The following is a description of a gene set: Pathway Definition from KEGG: LacCer -- >> B4GALT1/2/3/4 -> nLc4Cer -- FUT1*H -> TypeIIH // ABO*O Human Gene Set: KEGG_MEDICUS_REFERENCE_BLOOD_GROUP_H_O_ANTIGEN_TYPE_2_BIOSYNTHESIS species: Homo sapiens Blood group H (O) antigen type 2 biosynthesis. Pathway ID: N01666. Pathway type: Reference. Pathway class: nt06035 Blood group carbohydrate antigen biosynthesis., and this is the list of marker genes: B4GALT1 (NCBI Gene Id 2683), B4GALT3, ABO, FUT1, B4GALT4, B4GALT2 (NCBI Gene Id 8704), B3GNT5